Given this list of marker genes Gata6, Six2, Tbx6, Rtf1, Wnt3a, Ctr9, Smad1, Paf1, Hnf1b, Foxc2, Pax2, Bmpr1a, Sox17, Eya1, Nodal, Cdc73, Hoxa11, Etv2, Leo1, Ctnnb1, Sox2, Mesp1, Sfrp2, Pou5f1, Bmp4, Eomes, Dkk1, Elf5, Ets2, Nanog, Fzd7, Fgfr1, here is a description of the gene set: The commitment of cells to specific cell fates of the endoderm, ectoderm, or mesoderm as a part of gastrulation. Mouse Gene Set: GOBP_CELL_FATE_COMMITMENT_INVOLVED_IN_FORMATION_OF_PRIMARY_GERM_LAYER species: Mus musculus